The following is a description of a gene set: studied in species Mus musculus Mouse Gene Set: GOBP_ALKALOID_METABOLIC_PROCESS The chemical reactions and pathways involving alkaloids, nitrogen containing natural products which are not otherwise classified as peptides, nonprotein amino acids, amines, cyanogenic glycosides, glucosinolates, cofactors, phytohormones or primary metabolites (such as purine or pyrimidine bases)., and this is the list of marker genes: Th, Cyp3a44, Cyp3a41a, Nmnat2, Nmnat1 (NCBI Gene Id 70553), Cyp3a11, Cyp3a16, Nnmt, Cyp3a41b, Nampt, Nmnat3, Cyp1a2